The following is a description of a gene set: A chronic disorder of the liver in which liver tissue becomes scarred and is partially replaced by regenerative nodules and fibrotic tissue resulting in loss of liver function. Human Gene Set: HP_CIRRHOSIS studied in species Homo sapiens Cirrhosis, and this is the list of marker genes: LIPA, BMP2, CC2D2A (coiled-coil and C2 domain containing 2A), GALT, HAMP, F5, TFR2, SFTPC, ATP8B1, ACVRL1, FECH, IL21R, ABHD5, DOCK6, CEACAM6 (CEA cell adhesion molecule 6), SKIC3, TULP3, CFTR, TYMP, YARS1, SLC40A1, CALR, SEMA4D, RBPJ, TGFB1, ASL, CYP7B1, COG6, NPHP3, TERC, TJP2, MTTP, GBA1, TERT, SKIC2, GSTM3, WRAP53, TINF2, IGF2R, RTEL1, TMEM67, ABCB11, GPR35, SLC9A3, IL12A, CD40LG (CD40 ligand), ATP6AP1, HJV, HSD3B7, ATP7B, BSCL2, PHKG2, AP1B1, GCLC, CASP8, FOS, ARG1, MST1, ACBD6, SMPD1 (sphingomyelin phosphodiesterase 1), TCF4, KIF3B, PIK3CA, IRF5, NOTCH1, PPARG, DCDC2, NHP2, CTNNB1, AGPAT2, SLC11A1, TP53 (NCBI Gene Id 7157), CAV1, AP1S1, APOE, MUC5B, FAH, NGLY1, NPM1, CAVIN1, TNPO3, IFT56, SFTPA2, SPIB, CCDC115, SMAD4, HFE, RPGRIP1L, CP, ZFYVE19, JAK2, DLL4, TNFSF15, TRMT5, LBR, GLRX5, USB1, LIG3, TYMS, MARS1, GBE1, ARHGAP31, TFAM, MPI, PARN, SLC6A14, BMP6, KIF12, IFT43, ABCB4, SLC26A9, SLC25A13, MMEL1, PYGL, ITCH, PSMB9, HBB, MIF, DCTN4, CTC1, GDF2, POLG, FCGR2A, ENG, STX1A, PIGA, DHCR7, MET, EOGT, KCNN4, PDGFRL, SLC30A10, AXIN1, ALDOB, TALDO1, BCS1L, ALMS1, JAG1, MPV17, CEACAM3, RRM2B, PHKB, SLC7A7, SCARB2, EDNRA, PRIM1, DGUOK, POU2AF1, CLCA4, SERPINA1, KRT18, UROD, DKC1, IL12RB1, FARSB, PHKA2, HMOX1, TREX1, ATP6AP2 (NCBI Gene Id 95880), NOP10, APC, COG4, NR1H4, INPP5E, PKHD1, PEX1, MED12, ASS1